The following is a description of a gene set: The regionalization process in which specific areas of cell differentiation are determined along a proximal/distal axis of a nephron. The proximal/distal axis is defined by a line that runs from the center of the kidney (proximal end) outward (distal end). species: Homo sapiens Human Gene Set: GOBP_PROXIMAL_DISTAL_PATTERN_FORMATION_INVOLVED_IN_NEPHRON_DEVELOPMENT, and this is the list of marker genes: OSR1, IRX1, IRX2, HES5, IRX3